Given this list of marker genes RPL15, RPL35, RPS10, RPL27, RPL35A, FANCC, FANCE, MYSM1, STEAP3, RPL9, TSR2, RPS19, RPS7, PRF1, RPL18, RPS27, RPL31, TERT, RPS15A, SBDS, GATA1, FANCA, ADA2, RPS29, TERC, RPL11, HEATR3, RPS24, TCN2, RPS26, IFNG, RPL8, RPS28, RPS17, RPS20, FANCD2, RPL26 (ribosomal protein L26), RPL5, here is a description of the gene set: Human Gene Set: HP_RETICULOCYTOPENIA species: Homo sapiens A reduced number of reticulocytes in the peripheral blood. Reticulocytopenia